The following is a description of a gene set: studied in species Homo sapiens Genes in the cancer module 238. Human Gene Set: MODULE_238, and this is the list of marker genes: SPINT2, CLDN15, CMKLR1, ARHGAP25, TSPOAP1, MAP2K6, IGHG3, HVCN1, BIN2, TNFAIP2, FCRL2, KLHL41, MED12L, SELP, RIPK4, FCER2, ADAM28, ZNF395, COQ9, PNRC1, GLRA3, RUBCNL, SMCHD1, PLAC8, COA7, NME1, ZFHX2, TASL (TLR adaptor interacting with endolysosomal SLC15A4), PRKCB, RPAP3, ZNF587, KCNQ5, ITM2C, PDE2A, DNAH11, IL1R2, CDC25B, IRF8, PTX3, MTBP, HLA-DRB3, ADA2, MED29, SLC24A3, CD200, HMGN3, RCSD1, FCMR, TSPAN32, IL10RA, USP2, TTLL2, DIRAS2, C3orf36, SPRR1A, BLK (NCBI Gene Id 84743), SLC27A5, PLGLB2, KCNA3, SOX6, ATP2A3, UTY, VANGL1, XIRP1, ROR1, AMD1, MECP2, HIKESHI, DPEP2 (NCBI Gene Id 64174), TRDD3, BCL2, SEL1L, COL4A4, CTSZ, FLRT2, HDAC9, CSMD2, LRRC19, IL4R, SPATA20, HDLBP, DBP, COL19A1, ABCC5, FAM200C, TMEM97, RAX2, TXNIP, TRAF3IP3, CD24, FCRL1, TCL1A, IL24, CD5, CCDC186, BLOC1S5, STK33, ZNF423, TMEM79, ZNF292, MARCHF1, ZFP36L2, NTRK3, RSAD2, FAM53B, CXCR4, PRPF38B, G6PC3, ADGRE2, TAP1, PORCN, HEATR6 (NCBI Gene Id 63897), UNC5D, GABBR1, PRMT3, PTPRO, KIAA0753, TP53I13, CTSF, NR2E1, ALOX5, CACNG4, HSD17B11, VAV1, ITGB7, IGHM, CTLA4, RIPOR3, TRPC1, BACH2, SPON2, P2RY10, TCF7, BANK1, ANKRD28, TOR1B, OAS1, FCRLA, CNR2, SPPL2A, NAALADL1, FANCF, DEFA1, MED25, FADS3, FOXP1, NRIP2, DLC1, PLGRKT, PTPN6, SHC2, FGR, MX1, PTPN12, PTCRA, NACAD, TXLNGY, RAPGEF6, DGKD, NEK11, OSBPL10, SP110, TRAPPC13, RABIF